Given this list of marker genes SUMO3, NCALD, PRDM1, HMGN2, PPM1J, ITGB1, RAP2A, PRDX4, PMAIP1, S100A11, RAP1B (RAP1B, member of RAS oncogene family), SNX10, THEMIS2, NUPR1, ITGA1, CXCR6, RUNX2, MYBL1, TTC39C (tetratricopeptide repeat domain 39C), GABARAPL2, ATG5, GSAP, CTSD, MYO1F (myosin IF), NPTN, BLM, ARF6, RNF166, REEP5, CALM1, BSG (basigin (Ok blood group)), BSCL2, ACOT7, FGL2, RAD51, BAG1, CASP7, ZEB2, PLK3, HAUS4, ATOH1, L1CAM, ANXA1, ESCO2, F2R, LPIN2, LMNB1, CDC34, RORA, ASRGL1, PLEKHF1, DNAJB11 (NCBI Gene Id 51726), CHAF1B, PRR13, PRR11, IL12RB2, SPN, MTPN, STARD10, BSPRY, IFNGR1, MRPL57, NUDT4, SEPTIN11, ERN1, FKBP5, SMPDL3B, CD44, HCLS1 (hematopoietic cell-specific Lyn substrate 1), AS3MT, HIP1, ARHGAP18, RAB8B, IL18RAP, S100A13, EMP1 (epithelial membrane protein 1), DSTN, TUBE1, LAIR1, CHST11, ATF6, LAMC1, TBX21, GNPTAB, ORC6, PYCARD, PHACTR2, SWAP70, ATP2B4, SERPINB9, DOCK5, USH2A, BLVRA, GSR, MYADM, MCM4, IL18R1, ASPM, MPHOSPH6, GLRX (glutaredoxin), SYPL1, NIBAN1, H2BC4, H1-0, GEM, PACSIN2, SIRPA, HPRT1, PTPRJ, APOBEC2, RNF216, ALCAM, SGO2, PTPN13, HK2, MIS18BP1, AHNAK, HINT3, GPX8, SLA, PFKP, DPCD, CPD, CROT, RILPL2, NXT1, PTGR1, ITGAL, SLC25A24, SEC61B, GABARAPL1, IL1RL1, COX8A, OSBPL3, PIK3AP1, CDKN2B, ASF1B, PBK, CX3CR1, EHBP1L1, EPAS1, ENDOD1, CHSY1, CLSPN, ANXA4, HOPX, EME1, MXD1, DAPK2, RBM47, MYO5A, CD38, ITGAM, ID2, HTATIP2, SCPEP1, KLRC2, MYL4, ZDHHC2, CD80, GIMAP7, COBLL1 (NCBI Gene Id 22837), CRELD2, PTGES2, IFITM1, GALNT3, ITGAX, OTULIN, SEPHS2, PTPN12, MICAL1, TCF3, PGLYRP1, SAP30, NEIL3, DDX28, ZBTB32, VIM, TXNDC17, MCM5, here is a description of the gene set: from publication Parish IA, Rao S, Smyth GK, Juelich T, Denyer GS, Davey GM, Strasser A, Heath WR (PMID 19204323) Human Gene Set: GSE14699_DELETIONAL_TOLERANCE_VS_ACTIVATED_CD8_TCELL_UP Peripheral tolerance induction is critical for the maintenance of self-tolerance and can be mediated by immunoregulatory T cells or by direct induction of T cell anergy or deletion. While the molecular processes underlying anergy have been extensively studied, little is known about the molecular basis for peripheral T cell deletion. Here, we determined the gene expression signature of peripheral CD8+ T cells undergoing deletional tolerance, relative to those undergoing immunogenic priming or lymphopenia-induced proliferation. From these data, we report the first detailed molecular signature of cells undergoing deletion. Consistent with defective cytolysis, these cells exhibited deficiencies in granzyme up-regulation. Furthermore, they showed antigen-driven Bcl-2 down-regulation and early up-regulation of the pro-apoptotic protein Bim, consistent with the requirement of this BH3-only protein for peripheral T cell deletion. Bim up-regulation was paralleled by defective IL-7Ra chain re-expression, suggesting that Bim-dependent death may be triggered by loss of IL-7/IL-7R signaling. Finally, we observed parallels in molecular signatures between deletion and anergy suggesting that these tolerance pathways may not be as molecularly distinct as previously surmised. studied in species Homo sapiens Genes up-regulated in CD8 T cells: undergoing deletional tolerance versus activated.